Given this list of marker genes LITAF, NLRP12, RBCK1, IFI35 (interferon induced protein 35), LRRC19, CCL19, RHOA, RC3H2, FOXJ1, PRDX1, RC3H1, PTPN22, SPI1, TERF2IP, AGO3, MIR182, EIF2AK2, PPM1B, BIRC2, PYDC2, LIME1 (Lck interacting transmembrane adaptor 1), CALR, CPNE1, MIR132, IL12B, PTP4A3, BMP7, NLRC3, NR3C2, MIR15B, SASH1, TRIM26, IL18, MIR21, PYCARD, ADGRG3, EDA, TRIM56, BCL3, MKRN2, MIR204, MIR9-1, ZC3H12A, DAB2IP, C1QTNF3, TNFRSF11A, RIPK1, CCN3, NLRP3, SPHK1, IL23A, ZNF268, PHB2, NOD1, MIR149, TRIM44, TRIM60, PDCD4, UACA, EZR, HDAC7, ACTN4, C1QTNF4, NLRP2, LGALS9, MIR29B1, TREM2, NMI, AGER, NDUFC2, TRIM55, CYLD, NOL3, ADIPOR1 (adiponectin receptor 1), AGO1, MIR27B, HMGB1, MIR223, IL1B, TNFSF14, MAP3K7, IL18R1, DDX3X, GREM1, PHB1, TRIP6, EDAR, TNF (tumor necrosis factor), ADISSP, NOD2, CD27, TRIM6, DLG1, RASSF2, TCIM, TNFSF11, CD86, VCP, MIR766, EDN1, TRIM15, TRIM40, RTKN2, PPM1A (protein phosphatase, Mg2+/Mn2+ dependent 1A, NCBI Gene Id 5494), AKIP1, HAVCR2, RPS3, RELA, APP, MIR508, LAPTM5, here is a description of the gene set: Human Gene Set: GOBP_REGULATION_OF_NON_CANONICAL_NF_KAPPAB_SIGNAL_TRANSDUCTION studied in species Homo sapiens Any process that modulates the frequency, rate or extent of the non-canonical NF-kappaB signaling cascade.